Given this list of marker genes Tk2, Nmrk1, Tk1, Adk, Uck1, Dck, Uckl1, Nmrk2, Uck2, Dguok (deoxyguanosine kinase), here is a description of the gene set: studied in species Mus musculus Mouse Gene Set: GOMF_NUCLEOSIDE_KINASE_ACTIVITY Catalysis of the reaction: ATP + nucleoside = ADP + nucleoside monophosphate.